The following is a description of a gene set: species: Homo sapiens Enables the transfer of a solute or solutes from one side of a membrane to the other according to the reaction: Na+(out) + H+(in) = Na+(in) + H+(out). Human Gene Set: GOMF_SODIUM_PROTON_ANTIPORTER_ACTIVITY, and this is the list of marker genes: CHP1, SLC9A9, SLC9A8, SLC9A6, SLC38A3, SLC9C2, SLC9B2, SLC9C1, SLC9A2, SLC9A5, SLC9B1, SLC9A4, SLC9A1, SLC9A3, SLC38A5, SLC9A7